The following is a description of a gene set: electronically inferred by orthology from the curated human pathway species: Mus musculus part of: Cellular responses to stimuli Reactome Pathway: Cellular responses to stress This event has been computationally inferred from an event that has been demonstrated in another species.<p>The inference is based on the homology mapping from PANTHER. Briefly, reactions for which all involved PhysicalEntities (in input, output and catalyst) have a mapped orthologue/paralogue (for complexes at least 75% of components must have a mapping) are inferred to the other species., and this is the list of marker genes: Cox7a1, Oma1, H2bc13, Nr3c1, Mul1, Med1, Trp53, Sod3, Psma1, H2ac13, Psma5, Ajuba, Yme1l1, H2bc15, Hsbp1, H2ac24, Nbn, Rae1, Ccne1, Hspb8, Ep400, Tubal3, Atp6v0d1, Hspa1l, Tubb6, Phb2, Map2k6, Bmt2, Bag3, Dnajb6, Atp6v1d, Tubb4a, Rbbp7, Mre11a, H2ac23, Gpx8, Actr1a, Cox6a2, Tuba1a, Ufd1, Acd, Rheb, H2ac15, Psmd13, Lamtor5, Mapkapk5 (MAP kinase-activated protein kinase 5), Hdac3, Gpx6, Psmd7, Cycs, Cdk4, H1f3 (NCBI Gene Id 14957), H2ac19, Sirt1, Helz2 (helicase with zinc finger 2, transcriptional coactivator), Ubb, Ero1a, Hikeshi, Psmc2, H2ac10, Hspa2, Seh1l, Apob, Cdc23, Txnrd2, H2bc7, Txnrd1, Kdm6b, Map2k4, H2ax, H2bc1, Psma3, Ndufa4, Psmc3, Actr10, Carm1, Bag4, Hif1a, H4c8, Ywhae, Ccs, Wdr24, Map1lc3b, Nudt2, Ncor2, H4c2, Mink1, Psmc4, Ube2c, Akt1s1, Eef1a1, Cox6c, H2ac12, Psmc5, Psmb4, H4c17, Atp6v1f, Ube2e1, Epas1, Dynll1, Szt2, H2bc12, Wdr59, H2ac4, Jun, Apoa1, Crebrf, Cdkn1b, Ehmt1, Atp6v1g3, Hbb-bt, Psmc1, Cox4i1, H2ac1, Ets2, Cdc26, Psma6, Nox4, Higd1c, Esr1, H4c1, Cox7a2l, Tuba1c (NCBI Gene Id 22146), Sqstm1, Lamtor2, H1f5, Sesn2, Psmb7, Gpx3, Lmnb1, Cyba, Atp6v1a, Tuba3b, Sin3a, H2bc27, Lamtor4, Fkbp4, Eif2s3x, Psmd6, H4c14, Cited2, Vhl, Cox6a1, Psmb5, Mapk14, H4c3, Nup54, Mapk8, Ccna1, H2bc22, Tbl1x, H1f1, Dnajb1, Bag1, Erf, Fnip1, Ncf2, Nup210, H4c6, Rraga, Camk2b, Cox7c, Psma4 (proteasome subunit alpha 4), Mapk9, Atp6v1e2, H2ac11, Dync1li2, Nup155, Cdkn2b, Cox8a, Prdx3, Kics2, Ly96, Tuba4a, Flcn, H2bc3, Gstp1, Sod2 (superoxide dismutase 2, mitochondrial), H2ac22, Alb, Fzr1, Dctn6, Dctn1, P4hb, Nup85, Nup58, Kat5 (K(lysine) acetyltransferase 5), Mafk, Tcirg1, Atp6v1c2, Map2k7, Rps19bp1, Atp6v0e2 (NCBI Gene Id 76252), Atp6v1g2, Ccne2, Hsph1, Mapk11, Cul1, Blvrb, Hmox2, Hspa12a, Ndc1, Eif2ak1, Cryab, Atp6v0c, Map2k3, Nup93, H2ac6, Mapk7, Ep300, H4c4, Nup133, Cox8c, Cox4i2, Fnip2, Tubb2b, Rb1, H2ac8, H1f4, Rps27a, Hmga1, Anapc2, Psmd12, Tuba1b, Aaas, Atp6v0e, Ube2d1, Nup205, H4c9, Terf1, Terf2, Fos, Rbbp4, Tubb4b, Nup42, Prdx1, H2ac7, Castor2, Rragc (Ras-related GTP binding C), Anapc15, H2bc11, Eif2ak3, Hif3a, Psmc6, Gpx2, Cdkn1a (cyclin dependent kinase inhibitor 1A), Anapc7, Xpo1, Tuba8, Psma2 (NCBI Gene Id 19166), St13, H4c18 (H4 clustered histone 18), Psmb6, Tlr4, Mapk3, Ncf1, Txn1, Anapc10, H2bc9, Ezh2, Psma7, H4c12, Ube2s, H2bc8, Hsf1, Castor1 (cytosolic arginine sensor for mTORC1 subunit 1), H4c11, Rpa1, Hspa14, Lamtor1, H2ac20, Gpx7, Psmd1, H2az2, Prdx5, Ar, Cox5a, Gpx1, Vcp, Ncoa1, Pgrmc2, Hspa12b, Stoml2